Given this list of marker genes JADE2, IMP4, SUCLG2, NFKBIA, ATL2, ISL1, STK3, AKAP10 (A-kinase anchoring protein 10), CLSTN1, FEZF2, SP3 (Sp3 transcription factor), PHF8, CNOT1, KLC2, NBR2, RBM4, BRCA1, NFIL3, ZNF644, PBX3, GSTCD, CCNA2, GART, GDE1, ZBED5, CAPRIN1, PCDHGB4, MATR3, SON, GTF3C2, WNT11, INTS12, LHX6, RAD23A, HOXC10, TBC1D5, SYNCRIP, CLK1, PCGF1, TMEM187, NR2E1, CHTOP, RFX3, ATF2, EYA3, SFPQ, CSNK1E, PHF21A, JADE1, PRPS1, C1orf43, SEPTIN7, EP300, RBMX, KCNH2, TCTA, MEIS2, BHLHE41, RPS27, B4GALT1, YWHAE, EN1, UBE2D3, BMI1, CCDC115, YARS1, CCP110, RND3, HOXA10, PCDHGB5, DNAJC7, PPP1R12A, NKIRAS2, RHOA, HOXB8, PIGN, DHX15, STAG2, QRICH1, PPIG, IKZF3, here is a description of the gene set: Comprehensive identification of all functional elements encoded in the human genome is a fundamental need in biomedical research. Here, we present a comparative analysis of the human, mouse, rat and dog genomes to create a systematic catalogue of common regulatory motifs in promoters and 3' untranslated regions (3' UTRs). The promoter analysis yields 174 candidate motifs, including most previously known transcription-factor binding sites and 105 new motifs. The 3'-UTR analysis yields 106 motifs likely to be involved in post-transcriptional regulation. Nearly one-half are associated with microRNAs (miRNAs), leading to the discovery of many new miRNA genes and their likely target genes. Our results suggest that previous estimates of the number of human miRNA genes were low, and that miRNAs regulate at least 20% of human genes. The overall results provide a systematic view of gene regulation in the human, which will be refined as additional mammalian genomes become available. from publication Xie X, Lu J, Kulbokas EJ, Golub TR, Mootha V, Lindblad-Toh K, Lander ES, Kellis M (PMID 15735639) species: Homo sapiens Genes having at least one occurrence of the highly conserved motif M162 TAANNYSGCG in the regions spanning 4 kb centered on their transcription starting sites. The motif does not match any known transcription factor binding site. Human Gene Set: TAANNYSGCG_UNKNOWN